Given this list of marker genes C1qc, Capn2, Myh8, Gng11, Lgals3, Lgals3bp, Eif2b5, Cd68, C1qb, Or2c1, Fcrl2, Agt, Amh, Cd24a, Ctsh, Hexb, Bdnf, Pigf, Gfap (NCBI Gene Id 14580), Rpsa, Bcl2a1a (B cell leukemia/lymphoma 2 related protein A1a), Lmnb1, Efs, Iars1, Spp1, Trim30a, Psg-ps1, Gbp3, Ctsz, Mnat1, Nfya, Tgfbr3 (NCBI Gene Id 73753), Impa1, Dnajb2, Slc11a1, Ighm, Hmox1, Slc7a3, H2-Ab1, Sipa1l2, Acadvl, Tyms, Sez6, Hnrnph3, Zfp40, Ube2h, Ctsd, Cdk4, B2m, Irgm1, Hoxa4, Ctss, Tbc1d1, Snta1, Selplg, Apoe, Trappc5, C1qa, Notch1, Ifit1, Hoxd12, Wdfy3, Eps15, Tbx6, Ptpro, Mpeg1, Ptbp2, Cst7, Irf7, F2, Gnb2, Pglyrp1, Nos3, Axl, Fos, Hspa8, C4b, Eprs1, Ccl21b, Gck, Rhog, Nr4a1, Itgb5, Ifi27, Apc, Thbs2, here is a description of the gene set: from publication Lee CK, Weindruch R, Prolla TA (PMID 10888876) Ageing of the brain leads to impairments in cognitive and motor skills, and is the major risk factor for several common neurological disorders such as Alzheimer disease (AD) and Parkinson disease (PD). Recent studies suggest that normal brain ageing is associated with subtle morphological and functional alterations in specific neuronal circuits, as opposed to large-scale neuronal loss. In fact, ageing of the central nervous system in diverse mammalian species shares many features, such as atrophy of pyramidal neurons, synaptic atrophy, decrease of striatal dopamine receptors, accumulation of fluorescent pigments, cytoskeletal abnormalities, and reactive astrocytes and microglia. To provide the first global analysis of brain ageing at the molecular level, we used oligonucleotide arrays representing genes to determine the gene-expression profile of the ageing neocortex and cerebellum in mice. Ageing resulted in a gene-expression profile indicative of an inflammatory response, oxidative stress and reduced neurotrophic support in both brain regions. At the transcriptional level, brain ageing in mice displays parallels with human neurodegenerative disorders. Caloric restriction, which retards the ageing process in mammals, selectively attenuated the age-associated induction of genes encoding inflammatory and stress responses. Mouse Gene Set: LEE_AGING_CEREBELLUM_UP Upregulated in the cerebellum of aged adult mice (30-month) vs young adult (5-month) species: Mus musculus